The following is a description of a gene set: Genes containing one or more binding sites for (NR1H4) in their promoter regions (TSS -1000,+100 bp) as identified by GTRD version 20.06 ChIP-seq harmonization. Human Gene Set: NR1H4_TARGET_GENES studied in species Homo sapiens from publication Yevshin I, Sharipov R, Kolmykov S, Kondrakhin Y, Kolpakov F (PMID 30445619), and this is the list of marker genes: ATP6V0C, CAST, UGT2B10, CRKL, ZNF175, MIR6735, FBXW5, LRRC49, NABP1 (nucleic acid binding protein 1), TPPP2, NFYC-AS1, NFKBIA, VKORC1, PROK1, ALDOC, PDIA5, NRL, LACTB2-AS1, CYFIP2, MFSD2B, HLA-F-AS1, HSD17B2 (NCBI Gene Id 3294), EXOC3L4, STK40, GREB1L-DT, DMGDH, ALDH3A2, RTP3, ABCB11, MGAT4B, MIR191, PPARGC1A, BRINP2, C8G, MBD4, FLNB, CIBAR1, FNDC5, TBC1D17, GCGR, ZSCAN5A-AS1, TDO2, MAB21L3, CHPT1, LRIG2-DT, RNASE4, SELENOO, IFT70A, CYP2E1, CCNL1, ELFN1, RPL37AP1, PLG, HINT2, RGS3, FBXL19, TAGLN2, HRG-AS1, RN7SL435P (RNA, 7SL, cytoplasmic 435, pseudogene), LINC01588, DEAF1, TAT, C2CD3, COLCA1, SERGEF, ETS2-AS1, HBS1L, LTBP1 (latent transforming growth factor beta binding protein 1), SLC16A1-AS1, MTOR (NCBI Gene Id 2476), SZT2-AS1, DAPK2, MVD, ICAM1, LINC01151, ELP2, LINC02989, SREBF1, LINC00574, DRAIC, LINC02579, LTBP3, CNPY1, ELF3, ZNF512B, ZSCAN5A, SLIT1, TMEM63A, PTPRM, LINC02976, PLCG2, CTNS, PYROXD2, ARNT, MPC1-DT, TBC1D10B, TNS1, IQGAP2, LGI4, UST, HSPB1, TMED9, MIR100HG, FLVCR2, SNX31, POR, TACC2, HPS1, NQO2-AS1, CLMN (NCBI Gene Id 79789), FASN, WSB2 (NCBI Gene Id 55884), CFB, CFDP1, TMEM250, ASPDH, ACTN1, HDDC2, SPAG5-AS1, NTAN1, TNIP1, HORMAD2, TCEA2, CHKA, NOS1AP, ZNHIT1, ADH1B, SLC35A4, LINC02363, NDRG2, UROC1, FLNA, SNAI3-AS1, FCAMR, DIXDC1, TPST2, LINC02015, EPHA1, MASP2, SERPINA1, TMPRSS6, PNPLA6, ADH1A, MPRIP, RNA5SP334, NFYC, EHD1, ALDH2, AKT1S1, CDH23, SRGAP2C, ACY1, CLPTM1L, APOL3, SLC35E3, RPL39P5, HSD17B3-AS1, PITPNM1, ZNF30, GCK, ENSG00000187186, MFSD1, HPN, CHKA-DT, NBPF1, HORMAD2-AS1, SPATA20, PPAT, RILP, PLEC, TSG101, SUMF2, NDUFAF3, EFNA1, CYP4F3, CELSR1, LINC01978, SMG1P7, PLIN4, CAPN2, PTPA, GREB1L, TIE1, PITPNA, SPIN1 (spindlin 1), POLN, BAD, NBR1, IBTK, MROH7, CDC26, SARDH, SHPK, LINC01639, PRKCA-AS1, MLH3, RPL7P41, NOTUM, AJUBA, TRIM4, TSSC4, REXO4, SLC39A6, SLC43A3 (solute carrier family 43 member 3), TCF7L2, NDUFA6-DT, MICE, DDIT4, PRPF4, SEC14L2, COL4A2, KNG1, GGA1, UGT2B27P, DCAF11, CES3, AQP7, RN7SKP296, MGC32805, HEG1, LRIG2, ENSG00000271776, NR0B2, HRCT1, DAPK1, CGNL1, NFIC, SELENBP1, MPST, C4orf19, MPRIP-AS1, SLC16A1, MPDZ, SLC43A1, INS-IGF2, SLC10A1, ARHGEF2-AS1, CA5A, ZFP64, TCAP, ALG1L1P, U2SURP (U2 snRNP associated SURP domain containing), JUP, SLCO2B1, TMBIM1, SPATA1 (spermatogenesis associated 1), ITIH3, TOM1, TMEM8B, ENSG00000213963, ENSG00000226087, NAT8, UBC, CYB5A, ZNF815P, ARHGEF2, SLC51B, MCC, ECHDC2, GPLD1, SAA1, SH3YL1, ABI2, IFT140, DALRD3, TM4SF4, ITGB5, XRCC4, APBB3, C1QTNF6, NT5DC3 (NCBI Gene Id 51559), FAM72B, CPB2, GPRC5C, MAP3K8 (mitogen-activated protein kinase kinase kinase 8), GLYCTK-AS1, CDK5RAP2, PLA2G6, PHKA1, MYL11, NDST1, GLYCTK, C3P1, UGT2B4, LINC01702 (long intergenic non-protein coding RNA 1702), ENSG00000266767, SH3D19, C22orf39, CPSF3, IFT122, LINC01485, PSENEN, BCAR3-AS1, LEAP2, LRRFIP2, U2AF1L4, BATF, SMPD1 (sphingomyelin phosphodiesterase 1), TRAM1, AADAT, CDC34, EFHD1, AGXT, TGFBI, PPME1, SLC29A1, C1orf21, CIBAR1-DT, AOC4P, ATG10, SMG1P5 (NCBI Gene Id 595101), GCKR, SYBU, ENSG00000268129, ITGB1BP1, PHYH, POU2AF3, TNS2, SNX17, TUBE1, NOP14-AS1, DOCK6, BAZ1B, EIF2B4, PTPRN2-AS1, SREBF2, CSAD, UBAC2, CA14, C1orf226, PTRH2, ERICH6, PRODH2 (proline dehydrogenase 2), ITSN2, SNX3, APOA2, ADSS1, GSAP, RPL39P6, MNT, ZNF780B, UBAC2-AS1, CYP2D6, RNF111, GUCD1, BLTP3B-DT, HIRA, PFKFB1, RBP4, CPT2, SUSD1 (NCBI Gene Id 64420), KLF13, KMT2A, TMEM220, ACIN1, LNC-RHL1, SHTN1, FAM149A, SERPINB9P1, SLC25A18, LINC00222, NRP1, CIC, PIERCE2, CCPG1, TCP1, PTP4A2, ACKR2, MRPL18, RPS20P32 (NCBI Gene Id 100129306), B9D1, EPDR1, ARHGAP44, SLC27A3, ZMIZ2, TXNDC5, BICDL1, CAPN15, ZNF444, IKBKG, ENSG00000232876, AGPAT3, G6PC1, SERPINC1, MAPKAP1, MPC1, ENSG00000199566, LPCAT3 (lysophosphatidylcholine acyltransferase 3), TPRG1-AS1, NTHL1 (nth like DNA glycosylase 1), EIF1 (eukaryotic translation initiation factor 1), PECR, NQO2, KDM8, C3, PTMS, MOV10L1, MASP1, GLYATL1, INHBE (inhibin subunit beta E, NCBI Gene Id 83729), LINC01864, ANG, MYO18A, CYP3A43, HMGB1P8, SPG21, RBM23, PPP2R1B, CRIP2, ZNF30-AS1, MLF2 (myeloid leukemia factor 2), AMBP, RN7SKP8, AGT, LNCATV, MT2A, TMBIM6, ECH1, LINC01213, TAF6L, TTC7B, SDC1, TOP1MT, SLC27A5, HRG, FTCD (formimidoyltransferase cyclodeaminase), GLS2, FRMD6, C19orf12, ETNK2, ELF3-AS1, GPR84-AS1, GIT2